The following is a description of a gene set: studied in species Homo sapiens Human Gene Set: MODULE_139 Genes in the cancer module 139., and this is the list of marker genes: CYBA, SCNN1A, TPD52, AGR2, SYTL2, KRT8, SLC4A10, KRT19, ISOC1, RGCC, SULT2B1, GSE1, AIF1L, MLPH, MSI2, ELF3, ERBB3, C4B, NEBL, ANXA9, PRLR, UCP2, NSUN7, CYB5A, ARHGEF5, PRR15L, NHERF1, TRPS1, RERG, RHOB, ARHGEF16, IRX5, SELENBP1, ICA1, FOXA1, MAL2, ST3GAL5 (ST3 beta-galactoside alpha-2,3-sialyltransferase 5), NUP210L, CCN5, TJP3, CMAHP (cytidine monophospho-N-acetylneuraminic acid hydroxylase, pseudogene), B3GNT3, PKP3, SFT2D3, TP53I11, MAN1A1, UBXN6, RASL10A, ISY1, CDH1, CRABP2, RAB26, SYT17, GCA, EPCAM, MAGEA2, ANKRD50 (ankyrin repeat domain containing 50), OCLN, FBP1, BMP7, PDGFB, DPYSL5, VAV3, KRT18, BDH1, MSX2, MNX1, BLVRB, CLDN4, GPR160 (G protein-coupled receptor 160), CLDN7, TNFRSF25, SPINT2, SYT12, MUC1, MYO6, TFAP2C, GATA3 (GATA binding protein 3), BCAM